The following is a description of a gene set: Mouse Gene Set: GOBP_ACTIN_POLYMERIZATION_OR_DEPOLYMERIZATION Assembly or disassembly of actin filaments by the addition or removal of actin monomers from a filament. species: Mus musculus, and this is the list of marker genes: Cyfip1 (cytoplasmic FMR1 interacting protein 1), Clec2i, Arpc5, Prkcd, Diaph2, Cfl1, Wdr1, Gba2, Dbnl, Pfn2 (NCBI Gene Id 18645), Cyria, Mical2, Gm14137, Actr3, Was, Enah, Arhgap40, Bag4, Snx9, Ppp1r9b, Coro7, Capza1, Cfl2, Pak3, Baiap2l2, Fer, Ccl24, Brk1, Add2, Cdc42ep2, Cyrib, Naa80, Bbs4, Mtor, Dstn, Capg, Fam107a (family with sequence similarity 107, member A), Rhod, Aqp2, Wasl, Icam1, Twf1, Ssh1, Cyfip2, Arpc2, Cotl1, Gsn, Dmtn, Add3, Tmsb15b2, Alox15, Ghrl, Myadm, Myh9, Pik3ca, Myo1c (myosin IC), Nckap1l, Pik3r2, Flii, Ccl21e, Mtss1, F2rl1, Plekhg2, Rasa1, Cit, Arpc5l, Msrb1, Cracd, Mical3, Lmod2, Arf6, Tmod2, Ccl21d, Cdc42ep5, Capza3, Lmod3, Kirrel1, Nckap1, Hcls1, Slit2, Mical1, Tmod4, Baiap2, Prex1, Eln, Diaph3, Diaph1, Sptbn1, Ccl21a, Pecam1, Ccl26, Arhgap35, Nck2, Swap70, Plek, Shroom2, Fchsd2, Actn2, Catip, Cdc42ep3, Tpm1, Rdx, Cdc42ep4, Lats1, Washc5, Tmsb15l, Capn1, Arfgef1, Fchsd1, Svil, Sema5a, Rhoa, Scin, Tmsb4x, Kank1, Sptb, Evl, Msrb2, Carmil1, Cd2ap, Gas7, Hip1r, Fhdc1 (FH2 domain containing 1), Pfn5, Hax1, Vil1, Avil, Sh3bp1 (SH3-domain binding protein 1), Ccl21b, Arhgap28 (NCBI Gene Id 268970), Bin1, Grb2, Coro1a, Ccl11, Washc1, Abl1, Aif1 (allograft inflammatory factor 1), Cttn, Mtpn, Kank3, Esam, Prkce, Ang, Capzb, Daam2, Capza1b, Ppp1r9a, Add1, Washc3, Ssh3, Fmn1, Arpc3, Sptan1, Twf2, Vill, Ssh2, Mkks, Kank4, Pfn3, Ptk2b, Rictor, Cdc42ep1 (CDC42 effector protein 1), Carmil2, Spta1, Ttc17, Nphs1, Ghsr, Pdxp, Ccl21f, Csf3, Dbn1, Pycard, Pfn1, Lima1, Tmod3, Mlst8, Plekhh2, Rac1, Micall2, Dlg1, Tlr2, Kank2, Nck1 (non-catalytic region of tyrosine kinase adaptor protein 1), Cobl, Arpc4, Abitram, Baiap2l1, Tenm1, Specc1l, Capza2, Arhgap18 (NCBI Gene Id 73910), Spatc1l, Vasp, Map3k1, Lmod1, Fhod3, Eps8, Tmod1